The following is a description of a gene set: from publication Yevshin I, Sharipov R, Kolmykov S, Kondrakhin Y, Kolpakov F (PMID 30445619) studied in species Homo sapiens Human Gene Set: TSHZ1_TARGET_GENES Genes containing one or more binding sites for (TSHZ1) in their promoter regions (TSS -1000,+100 bp) as identified by GTRD version 20.06 ChIP-seq harmonization., and this is the list of marker genes: LUCAT1, LAMA4, PLD1, CCN1, POLG-DT (POLG divergent transcript), RNF139-DT, SH2D5, HEXIM1, SIM1, MOK, CRLF2, CDC42EP4, TMEM114, NAA16, SIX2, ALG11, EFHC1, KBTBD4, REXO4, LINC00649, SPPL3, SLC49A4, CNOT6L, SLIT3-AS1, LINC02960, LCN15, RANGRF, TMEM121B, EXD2, TMEM79, CCT6B, MCM7, EPHA3, ITPRIP, AFF1, PIGL, CALN1, ATP7B, NCAM1, ALKBH3-AS1, ATAD2, BACH1, MAPK4, DNAJB6 (DnaJ heat shock protein family (Hsp40) member B6), TBPL1, LINC01664, CBFA2T2, BRINP2, HIVEP3, LBX1-AS1, PCID2, LINC02846, CAPZA2, LINC02831, TOP3B, SUDS3, ALDOA, S100A2, SMAD1, GTPBP6, LINC02609, GSTCD, HMGA2, GALNT16-AS1, LINC01775, LINC01411, DZIP1L, KDM4B, KRBA1 (KRAB-A domain containing 1), MIR4999, LAMP1, ZNF503-AS2, HEXA, MIR5188 (microRNA 5188), SKIDA1, NFIB, CGA, EMC1-AS1, ITGB3BP, SMG7-AS1, H4C2, VANGL1, TAGLN2, KDM1A, MTF2, ZNF593, POLG, GTPBP3, WDR62, LINC01275, BRWD1, LRRC41, CLASP2, NDUFS7, TTC1, PLEKHM1, JOSD1, TLK2, NXN (nucleoredoxin), GBA1, ITGA7, ARHGEF12, TLCD3B, JMJD4 (NCBI Gene Id 65094), NDUFS3, SLC6A6, ZNF253, TM7SF3, IGF2BP3, CCDC144BP, MIR615, TBC1D22A, GZF1, VIM, ENSG00000278356, PIP5KL1, DRAIC, CCNI, CDC42SE1 (NCBI Gene Id 56882), KLHDC9, HSPBAP1, NR2F1, MVK, SPAG9, BRPF1, ST6GALNAC2, AJUBA-DT, PRECSIT, ACAP3, NCOR2 (NCBI Gene Id 9612), STAT6, TSHZ2, KCNK1, CLTC, TRMT2A, DLK2, CCDC192, ETV4, ZNF503, ZNF217, MSANTD3 (Myb/SANT DNA binding domain containing 3), DRG2, CLIP1, PKNOX1, KCNB1 (potassium voltage-gated channel subfamily B member 1), MEIS2, TMEM260 (transmembrane protein 260), GABPB2, CTNNB1, UBR4, PANTR1, RBL1, LINC01010, TLE6, TBL1X, RRAS2 (NCBI Gene Id 22800), EFCAB7, CCBE1, EGLN2, EPS15-AS1, RNF43, TIPRL, MDM2, VWA8, RFTN1, MSRB2, CBX4, UBC, ASCC1, ZCCHC2, LRFN3, DHRS3, HES4, CREM (cAMP responsive element modulator), ALDH1A2, PKNOX2, HOXB-AS3, TLE1, DLEU1, LY6K, RNVU1-27, ZNF555, ISG15, ZNF790, ELP3, PIM1, LCORL, SMIM2-AS1, INTS12, ZNF608, GTF3C5, CCDC159, IGF1R, SACM1L, SNAP47, RPL37, MIR194-1 (microRNA 194-1), RNF139, ENSG00000247416, PAXBP1, LINC01132, MAML3, MTFR2P2 (MTFR2 pseudogene 2), SMG5, HOXB9, GLI3, MCC, TOB2, ANO8, GABARAP, RAB11B-AS1, LINC00963, RAB11B, EIF2B3, NRP1, KIAA0319, HOXB3, HEXA-AS1, RNU6-1039P, KRT75, BCAS3, AJUBA, TMBIM6, AP4M1 (adaptor related protein complex 4 subunit mu 1), SMG7, LINC00431, RANBP1, PKNOX2-DT, CLPB, SNHG17, TMEM101, ABCB4, HOXA5, YJU2B, MYH9, EPCIP-AS1, SMARCD2, ARB2A